The following is a description of a gene set: Translation studied in species Homo sapiens Human Gene Set: REACTOME_TRANSLATION, and this is the list of marker genes: EEF1A1, RPL36A, GSPT2, SSR1, MRPL33, MT-RNR2, AIMP1, MRPS23, MRPL51 (mitochondrial ribosomal protein L51), RPS17, SEC61A2, RPL28, MRPL11, EIF2S1, EIF4EBP1, MRPS14, MRPS18B, RPS25, MARS1, MRPL1 (mitochondrial ribosomal protein L1), EIF4H (eukaryotic translation initiation factor 4H), MRPL50, VARS2, MRPL17, N6AMT1, MRPL57, APEH, MRPL47, RPL6, GSPT1, RPL27 (ribosomal protein L27), MRPS27, RPS15A, FARSB, GFM2, RPL18A, SEC61B, IARS1, RPS16, EIF4G1, HARS2, MRPS18C, EIF3H, MRPL42, AIMP2, TARS1, RPS4Y1, MRPL21, RPL32, GARS1, RPL26L1, MRPS25, UBA52, MRPL12, RPS12, MRPL53, RPS20, RPS11, MRPS17, RPS27L, FARSA, RPS23, SSR4, MRPS18A, EIF3K, PARS2, EARS2, SRP68, HARS1, KARS1, EIF4E, RPL23A, MTIF2, CARS2, MRPL20, MRPS2, MRPS31, MRPL23, RPL21, RPS7, MRPL54, EIF3M, RPL38, RPL10, RPL26, LARS1, CARS1, RPL22L1, EIF5B, EIF3E, RPL7, SRP54, ETF1, DARS2, MRPS35, MRPS21, RPN2, RPS29, RPL19, OXA1L, RPL39L, RPS21, EEF2, EIF4A1, MRPL44, KGD4, RPS15 (NCBI Gene Id 6209), EIF4A2, RPS8 (ribosomal protein S8), MRPL13, RPL11, AURKAIP1, MRPS22, ERAL1, RPL10L, EEF1A2, SEC61A1, RPS27, RPSA, GADD45GIP1, EIF3D, SSR2, GFM1, RPL15, MRPS10, EIF3A, MRPL18, RPL29, MRPS15, RPL36AL, FARS2, MRPL4, MRPL3, RPL13A (ribosomal protein L13a), RPS2, RPL35, PPA1, RPL30, MRPL40, SEC11A, WARS2, PTCD3, RARS1, EEF1B2, RPS5, QARS1, MRPL36, RPL35A, RPS4X, MTRF1L, MRPL22, VARS1, DARS1, MRPS34, MRPL37 (NCBI Gene Id 51253), RPS9, MRPL43, RPS24, PABPC1, MRPL15, RPL31, RPL36, RPL10A, SRPRB, RPS3, TSFM, SPCS2, EIF2S3, SRP9, RPS27A, SRP72, RPS10, SEC11C, RPS19 (NCBI Gene Id 8378), RPL4, RPL39, RPS18, MRPL58, MRPL46, SEC61G, EIF3L, RPL22, TRMT112, RPS26, EIF3J, RPS3A, RARS2, MRPS26 (NCBI Gene Id 81568), MRPS28, MRPS7, EIF2B5, MRPL48, MRPL24, RPL8, MRPS16, MRPS30, EIF2B3, EIF2S2, MRPL39, MRPL27, EEF1E1, RPLP0, EEF1G, EIF3B, MRPL28, EIF2B4, MRPS11, RPL5, MRPS24, MRPL52, TUFM, MRPL35, EIF2B1, RPS13, RPL23, RPL18, TRAM1, MRPS6, MTFMT, MRPL30, EPRS1, RPL14, SSR3, RPL7A, RPL27A, MRPL34, AARS1, RPS4Y2, DDOST, RPL34, SRPRA, MRPL16, CHCHD1, RPL41, MRRF, MRPL55, RPL24, MRPL32, EIF3G, SARS2, SPCS3, NARS2, SARS1, MRPL49, RPN1, MRPL38, EEF1D, RPS14, NARS1, RPL37A, EIF4B, MT-RNR1, EIF1AX, SRP14, EIF2B2, YARS1, LARS2, RPLP1, SRP19, EIF3I (NCBI Gene Id 8668), RPL12 (ribosomal protein L12), MRPL14, MRPS12, MRPL2, MRPS33, MRPL41, MRPS9, MRPS5, MRPL19, MRPL9, MRPL45, MARS2, EIF3F, RPS6, RPL37, RPS28, MRPL10, PPA2, DAP3, IARS2, MTIF3, FAU, RPLP2, AARS2, SPCS1, RPL3, WARS1, RPL13, EIF3C, RPL3L, RPL17, EIF5, RPL9, TARS2, YARS2